The following is a description of a gene set: This event has been computationally inferred from an event that has been demonstrated in another species.<p>The inference is based on the homology mapping from PANTHER. Briefly, reactions for which all involved PhysicalEntities (in input, output and catalyst) have a mapped orthologue/paralogue (for complexes at least 75% of components must have a mapping) are inferred to the other species. electronically inferred by orthology from the curated human pathway part of: Cytokine Signaling in Immune system Reactome Pathway: TNFR2 non-canonical NF-kB pathway species: Mus musculus, and this is the list of marker genes: Tnfrsf18 (tumor necrosis factor receptor superfamily, member 18), Psmc4, Psmc5, Tnfrsf13c, Tnfrsf11a, Tnfsf13, Traf3, Psmc3, Tnfrsf4, Eda, Cd70, Birc3, Tnfsf12 (NCBI Gene Id 21944), Tnfrsf14, Tnfsf15, Tnfrsf17, Psmb5, Psmc6, Psmc2, Tnfrsf25, Psmd7, Tnfsf14, Ubb, Psma7, Tnfsf18, Cd27, Psma3, Cd40lg, Psmb4, Psmd12, Psmd6, Ltb, Tnfsf11, Tnfrsf11b, Tnfrsf1a, Tnfsf8, Lta, Tnfrsf1b (NCBI Gene Id 21938), Psmb6, Psma5, Tnfsf9, Psma2, Psma4, Psma6, Psma1, Map3k14, Rps27a, Relb, Psmd1, Psmd13, Cul1, Tnf, Psmc1, Nfkb2, Psmb7